The following is a description of a gene set: Human Gene Set: HP_DIFFICULTY_RUNNING species: Homo sapiens Difficulty running Reduced ability to run., and this is the list of marker genes: GMPPB, PNPLA2, TTN, SGCG, ATP2A1, SFXN4, DPAGT1, BIN1, MEGF10, STIM1, KY, RAPSN, RYR1, SNUPN, PYROXD1, MFN2, FKRP, COL12A1, KCNC3, SPEG, ADSS1, GFPT1, REEP2, LMNA, FBXO38, ALG14, DNAJB6, AGRN (NCBI Gene Id 389836), MICU1, VMA21, NEFL, YARS1, COL6A1, KBTBD13, LAMA2, FHL1, ALG2, MYH7, VCP, RYR3, TPM3, POPDC3, TCAP, DYNC1H1, REEP1, PEX2, ANO5, MYPN, BICD2, FLNC, DYSF, TPM2, TNPO3, MT-TE, MORC2, TNNT1